The following is a description of a gene set: Human Gene Set: WP_VASOPRESSINREGULATED_WATER_REABSORPTION studied in species Homo sapiens Vasopressin-regulated water reabsorption, and this is the list of marker genes: DCTN1, DYNC1LI1, NSF, DYNC1I2, DYNC2LI1, DYNC2H1, AVP, PRKACB, ADCY6, ADCY3, AQP4, AQP3, DYNLL1, PRKACA, RAB5C, DYNC1H1, CREB3L3, CREB1, DYNC1I1, RAB5B, DCTN2, DCTN5, GNAS, CREB3L2, CREB3L4, VAMP2, PRKACG, DYNLL2, ADCY9, ARHGDIB, ARHGDIA, DCTN4 (dynactin subunit 4), RAB11B, RAB5A, AQP2, DYNC1LI2, CREB5, RAB11A, DCTN6, ARHGDIG, AVPR2, STX4, CREB3, CREB3L1 (cAMP responsive element binding protein 3 like 1)